The following is a description of a gene set: studied in species Homo sapiens Human Gene Set: GOBP_REGULATION_OF_NUCLEOCYTOPLASMIC_TRANSPORT Any process that modulates the frequency, rate or extent of the directed movement of substances between the nucleus and the cytoplasm., and this is the list of marker genes: APOD, GLI3, SMO, PRP4K, TPR (translocated promoter region, nuclear basket protein), PRKD1, IL1B, BAG3, SIRT6, JAK2, CABP1, FLNA, FRAT1, NF1, RAPGEF3, EPM2A, HYAL2, TRIM28, SUFU (NCBI Gene Id 51684), LEP, XPO1, EP300, FERMT1, NFKBIA, SFN, ANP32B, NUP58, CDK5, SMAD3, CAMK1, HDAC3, JUP, TGFB1, WNK1, UHMK1, EI24, RIOK2, SUMO1, ZIC1, IFI27, BARD1 (BRCA1 associated RING domain 1), KHDRBS1, PIK3R2, CHP1, PKIA, GAS6, EFCAB7, AKAP8L, NRDE2, CDH1 (cadherin 1), IWS1, IPO5, BMP4, ECT2, MDM2, TARDBP, YWHAE, MAVS, PPP1R12A, ZPR1, NSUN2, RAN, IER3, RANGAP1, PKIG, ALKBH5, DMAP1, SHH, HHEX, MDFIC (MyoD family inhibitor domain containing), PPP1CC, CDKN2A, SETD2, PPM1A, PARK7, TMEM53, CTDSPL2 (NCBI Gene Id 51496), DHX9, PTPN11, CHP2, AAAS, UFM1, TXN, CD36, MAPK14, XPO4, RAB23 (RAB23, member RAS oncogene family), NUP214, UBR5, HSP90AA1, PSEN1, CDK1, YWHAB, PRKCD, ZC3H12A, SIRT7, CPSF6, THOC2, RBM4, PIK3R1, SP100, NEDD4, HCLS1, ANGPT1, FAM76B, NEAT1, XBP1, RBM22, PTPN14, RBM10, NCBP2, MX2, DDX39A, NUP153, IFNG, GSK3B, FRAT2, CWH43, PRKACA, EMD